Given this list of marker genes CYP2D6, HPGD, ALOX5AP, LTC4S, CYP2E1, GSTM4, GPX4, ALOX5, ALOX12, CYP3A4, PTGR1, EPHX2, LTA4H, CYP2C9, CYP1A2, CYP2C8, CYP1A1, ALOX15, PTGS2, here is a description of the gene set: Biosynthesis of specialized proresolving mediators (SPMs) Human Gene Set: REACTOME_BIOSYNTHESIS_OF_SPECIALIZED_PRORESOLVING_MEDIATORS_SPMS species: Homo sapiens